Given this list of marker genes MFAP3L, ZNF462, SLC15A2, ZXDC, FCF1, GLDC, B4GALT2, PTPRK, MAPKAPK5, SCN2B (NCBI Gene Id 6327), ASTE1, TPT1, ZFHX4, NAA30, KMT2A, SOX6, JADE1, NEU1, MATN1, MBTD1, TLCD3A, KCNJ13, BSDC1, PPTC7, KLF2, EMX2, SMIM7, WTAP, BAAT, SMG7, DLX4, SRPX2, RDH10, DEDD2, HIPK3 (NCBI Gene Id 10114), DENND1B, KCNA6, ATG10, GALNT7, ALOX12, SPG21, SERPINB8 (serpin family B member 8), PDE3B, HOMER1, BIVM, ZCCHC10, MBTPS2, DNAAF11, GTPBP1, LHX8, ATRN, ATG7, GOPC, MGARP, ZNF426, MEOX1, SPRY3, TEK, WDR17, WDR36, SOS1, RAB22A, BTBD7, OTUD7B, C1QL1, TRAK1, FGG, RGS10, C6orf120, PSD3, LCP2, RMND5A, ZFP36L1, CALU, WT1, CELSR3, AGO2, VWA3B, DYNLL1, SEC62, KCNE1, here is a description of the gene set: Genes predicted to be targets of miRBase v22 microRNA hsa-miR-1910-5p in miRDB v6.0 with MirTarget v4 prediction scores > 80 (high confidence targets). from publication Chen Y, Wang X (PMID 31504780) studied in species Homo sapiens Human Gene Set: MIR1910_5P